The following is a description of a gene set: Any process that activates or increases the frequency, rate or extent of activity of the transcription factor NF-kappaB. Mouse Gene Set: GOBP_POSITIVE_REGULATION_OF_NF_KAPPAB_TRANSCRIPTION_FACTOR_ACTIVITY species: Mus musculus, and this is the list of marker genes: Tnfsf11, Traf5, Cd40lg, Tlr4, Irak2, Slco3a1, Psma6, Ripk3, Trim38, Clock, Mtdh, Arhgef2, Card9, Trim62, Trim5, Camk2a, Cd84, Trim12c, Traf2, Tlr2, Carm1, Rab7b, Ppia, Cth (NCBI Gene Id 99582), Wnt5a, Myd88, Trim52, Il1b, Ltf, Nlrp3, Dhx33, Tgfbr3, Trim25, Rnf31, Ikbkb, Trim32, Rhebl1, Prkcz, Zbtb7a, Irak3, Dhx9, Ankrd42, Ntrk1, Malt1, Ins2, Lamtor5 (late endosomal/lysosomal adaptor, MAPK and MTOR activator 5), Bcl10, Traf1, Pycard, Trim13, Nod1, Rps3, Aim2, Irak1, Il18r1, Trim8, Prkd2, Sphk1, Prkcq (protein kinase C, theta), Ins1, Tlr3, Nlrc4, Traf6, Cd40, Trim30d, Rnf25, Ager, Tirap, Prkch, Trim12a, Erc1, Trim14, Card14, Nts, Tfrc, Nod2, Tnfrsf11a, Npm1, Grem1, Lrrfip2, Eif2ak2, Ripk4, Rbck1, Rps6ka5, Terf2ip, Capn3, Il18, Fer, Ror1, Card11, Trim15, Tnfsf18, Mid2, Hspa1b, Prdx3, Trim30c, Trim30a, Map3k13, Lrrfip1, Cflar, Trim37, Trappc9, Ikbkg, Il18rap, Mtpn, Ripk2, Ticam1, Prkd1 (protein kinase D1), Prkci, Ar, Rela, Clu, Trim30b, Crnn, Cib1, Il1rap, Ripk1, Ddrgk1, Ube2n, Tnf, Rtkn2, Cat